The following is a description of a gene set: species: Mus musculus Mouse Gene Set: chr3H2, and this is the list of marker genes: Gm19104, Clca3a1, Gm5857, Gm9419, Uox (NCBI Gene Id 99701), Ssx2ip, Mcoln3, Gm17743, Gm10288, Gm29771, Gm36888, Gng5, Gm6074, Ttll7, Gm16215, Dnase2b, Clca1, Ctbs, Gm9480, Gm16325, Ddah1, Clca3b, Gm35409, Gm36259, Gm36831 (NCBI Gene Id 102640866), Clca3a2, Rpl36a-ps2, Gm43560, Bcl10, Gm34078, Syde2, Gm42707, Gm17501, Mcoln2, Spata1, Gm25627, Lpar3, Prkacb, Gm16233, Gm34866, Gm35066 (predicted gene, 35066), Samd13, Rpl9-ps8, Selenof (NCBI Gene Id 93684), Ccn1, Hs2st1, Clca2, Sh3glb1, Rpf1, 2410004B18Rik, D530037P16Rik, Gm10636, Odf2l, Clca4a, Gm43707, Lmo4, Dnai3, 9530034A14Rik, Znhit6, Clca4b, Col24a1, Gm22078